The following is a description of a gene set: Genes up-regulated in comparison of ex vivo CD8 dendritic cells versus cultured CD8 DCs. The functional relationships and properties of different sub-types of dendritic cells (DC) remain largely undefined. We used a global gene profiling approach to determine gene expression patterns among murine splenic CD11c high DC subsets in an effort to better characterise these cells. from publication Edwards AD, Chaussabel D, Tomlinson S, Schulz O, Sher A, Reis e Sousa C (PMID 12816982) studied in species Homo sapiens Human Gene Set: GSE339_EX_VIVO_VS_IN_CULTURE_CD8POS_DC_UP, and this is the list of marker genes: TNPO2, IL16, MYCL, SNX5, USP4, MRPL40 (NCBI Gene Id 8699), KLHL7, TEX261, CCNB2, DCAF8 (DDB1 and CUL4 associated factor 8), KLF3, RBM14 (NCBI Gene Id 96086), NEK7, CNIH1, MTARC2, LY86, SLC8A1, LAT2, NAGLU, PPT2, ABCD1, PDE7A, TRIM28, NISCH, EVL, SELENOT, POMP, GBF1, TCF19, HINT2, DHX16, MICOS13, TXNDC16, ZNF274, RPS6KC1, UBA2, PTPN18, FKBP4, SGPP1, FGF5, PBX3, LIMD1, MFSD14B, BOLA2, ARL6IP1, UNC119, VAMP2, LIMD2, KLF4, HDAC2, DCTN6, ARHGAP9, FAM3C, FAAP20, WAS, TRIM13, XRCC6, CIB1, DNAJC7, RFC1, CACYBP, TMED4, PPP1R21, CDK14, B3GALT4, EIF2AK4, CASP2, ISOC1, FAM91A1, COLGALT1, CLTA, SOS1, SYCE2, DDOST, SMAD1, UNC119B, NUSAP1, PGLS, FLOT1 (NCBI Gene Id 10211), GARS1, AK3, ANPEP, GPSM3, DACH1, STAM, PTOV1, LRPPRC, GALNT1, BTK, COPS3, SETDB1, RNF166, H1-0, RASA3 (NCBI Gene Id 22821), H2AX, TMEM126A, ZFP36L2, CDK1, NEURL4, TMEM230, MYADM, FLT1, DALRD3, NEDD1, LDAF1, PPOX, SSBP4, ABCB1, KDM3B, MARVELD1, TSC2, APOE, FCHO1, CIC, ZBED3, IER2, UBE2N, PARP2, ECI2, MACROH2A1, EIF4EBP2, XPR1, MRPS26, PRDX2, ARID3B, ASNSD1, NUDT19 (nudix hydrolase 19), CDC123, NUDT21, SLK (NCBI Gene Id 9748), PPP1R18, RGS2, PXK, TOB1, SMIM7, RER1, HELLS, POLR3K, CDC5L, SMAD2, LEPROT, SURF1, ASAH1, MAP2K6, NR2F6, NLK, DOCK5, MICOS10, SPTSSA (NCBI Gene Id 171546), RAMP1, LPIN1, INTS3, TPP2, ATRAID, ORMDL2, ITM2A, SUMO3, SLC37A4, RASAL3, CCDC12, PECAM1, CCDC186, CHD8, ADAM23, ILF2, DUSP19, GLUD1, GATM, ZNF207, CINP, MRPL18, POLR2G, HFE, PSME4, SMC2, FADD, KIAA0319L, MAN2C1, ZZZ3, SCP2, LYL1, PRKCB, RAD50, HOXA3, GOLGA5, RNF13, KIF20A, CRTAP, ITPR1, RGS10, NEK2, CDC25A, HMBOX1, HNRNPR, ZKSCAN3, DDHD2, GLCE, AIFM1, GUSB, ST3GAL5